Given this list of marker genes Rbpj, Mageb3, Invs, Mllt10, Purb, Lpo, Wnk1, Ube2s, Chd5, Clcn7, Clcn4, Tnpo1, Themis, Dcaf10 (DDB1 and CUL4 associated factor 10), Wtap, Taf2, Triqk, Cnr1, Prpf40a, Pik3r1, Clic5, Sap30, Nfyb, Csmd1, Abhd2, Fmr1, Taf6, Rgs19, Nod2, Dusp29, Swt1, Iqschfp, Zfp93, Rbl2, Ppp2r5c, Matn2, Clint1, Calhm5, Scgb2b2, Gpcpd1 (glycerophosphocholine phosphodiesterase 1), Ube2g1, Cdcp1 (CUB domain containing protein 1), Bard1, Ptprj, Nkx2-1, Kif5c, Ifi205, Pycr3, Phf5a, Cacnb4, Shisa3, Wdr82, Mcm6, Ddx5, Lhx2, Rrbp1, Rpp14, Usp33, Ifi211, Trnt1, Etnk1, Tmx1, Wdr44, Wwtr1, Socs5, Schip1, Vxn (vexin), Gnl3l, Scgb2b1, Cckar (cholecystokinin A receptor), Ppp3cb, Rb1cc1, Sesn3, Plekhf2, Dusp12, Minar1, Ppp1r15b, Gadl1, Rbm7, Pcnx2, here is a description of the gene set: Genes predicted to be targets of miRBase v22 microRNA mmu_miR_7054_3p in miRDB v6.0 with MirTarget v4 prediction scores > 80 (high confidence targets). from publication Chen Y, Wang X (PMID 31504780) species: Mus musculus Mouse Gene Set: MIR_7054_3P